Given this list of marker genes CACNA1G, MIR208A, CACNB2, SCN5A, CACNA1C (calcium voltage-gated channel subunit alpha1 C), TRPM4, here is a description of the gene set: The process in which AV node cardiac muscle cell membrane potential changes in the depolarizing direction from the negative resting potential towards the positive membrane potential that will be the peak of the action potential. Human Gene Set: GOBP_MEMBRANE_DEPOLARIZATION_DURING_AV_NODE_CELL_ACTION_POTENTIAL species: Homo sapiens